Given this list of marker genes FASLG, EPG5, RFXAP, RASGRP1, CASP8, TNFRSF13B (NCBI Gene Id 23495), CARD11, RNU4ATAC, CD247, ESS2, MCM10, FOXN1, KRAS, MGAT2, MRTFA, RAB27A, RFXANK, SLC39A4, TGFB1, IL2RG, AK2, PIK3CD, LIG1, ZAP70 (NCBI Gene Id 7535), COMT, PSMB10, IL7R, PNP, LEPR, COG6, WAS, LCP2, IKBKB, KNSTRN, RAC2, RNF31, LEP, UMPS, TNFRSF13C, CARMIL2, CD3E, CTPS1, CD19, EXTL3, JAK3, SYK (spleen associated tyrosine kinase), CD3D, NSMCE3, CD40LG, DGCR2, TNFRSF9, PGM3, IL2RA, UFD1 (ubiquitin recognition factor in ER associated degradation 1), ARVCF, HLA-DRB1, DOCK2, NRAS, SMARCAL1, MALT1, DGCR8, CIITA, HIRA, RREB1, MAGT1, LAT, FAS, POLD3, DGCR6, WIPF1, RAG1, TBX1, GATA3 (NCBI Gene Id 84828), CASP10, SLF2, SEC24C, STAT1, CD27, RFX5, ADA, JMJD1C, GP1BB, CR2, RAG2, ICOS (inducible T cell costimulator), here is a description of the gene set: A functional anomaly of T cells. Abnormality of T cell physiology Human Gene Set: HP_ABNORMALITY_OF_T_CELL_PHYSIOLOGY species: Homo sapiens